The following is a description of a gene set: Human Gene Set: HP_IRIS_HYPOPIGMENTATION Iris hypopigmentation species: Homo sapiens An abnormal reduction in the amount of pigmentation of the iris., and this is the list of marker genes: HPS1, CDH23, KCNAB2, HSPG2, SOX10, PRPH2, MAGEL2, KANSL1, NDN, SPEN, LYST, USH1C, BLOC1S5, PRDM16, HARS1 (NCBI Gene Id 3035), SLC45A2, XYLT2, GABRD, BEST1, ADGRV1 (adhesion G protein-coupled receptor V1), DTNBP1, CLRN1 (NCBI Gene Id 7401), RERE, RAB27A, PCDH15, ESPN, GPR143, SNRPN, HPS6 (NCBI Gene Id 95477), SKI, BLOC1S3, PDPN, USH1G, AP3B1, USH2A, TYR, UBE4B, IMPG2, OCA2, MLPH, MT-TS2, WHRN, PITX2 (paired like homeodomain 2), EPG5, TYRP1, MMP23B, IMPG1, ATP10A (NCBI Gene Id 57194), MYO7A, HPS5, CIB2, MC1R (melanocortin 1 receptor), PDZD7, CASZ1, LUZP1, UBE3A, CEP78, PRKCZ, AP3D1, BLOC1S6, MYO5A, HPS4, ARSG